Given this list of marker genes Ppp2r3c, A2m, Evpl, Il17a, Cd55b, Il17f, Pgc, Spns2, Gimap5, Ptpn6, Cd37, H2-DMa, Serping1, Cd55, Cr2, Lta, Nod2, Ppl, Fcgr2b, Gata6, Cd46, Klk7, Hpx, C4bp, Mbl2, Zp3, Foxj1, Klk5, Ivl, C3, Cr1l, Fcer2a, Tnf (tumor necrosis factor), Cd5l, Il1b (interleukin 1 beta), C1qbp, Ptprc, Gimap3, Masp1, Susd4, Acod1, Phb1, Cd59b, Cfhr4, Cfh, Vsig4, Zp3r, Cd59a, Trem2, Ccr7, here is a description of the gene set: species: Mus musculus Mouse Gene Set: GOBP_REGULATION_OF_HUMORAL_IMMUNE_RESPONSE Any process that modulates the frequency, rate, or extent of a humoral immune response.